The following is a description of a gene set: studied in species Mus musculus Genes negatively differentially expressed in cell type: cDC1 (conventional dendritic cell type 1) upon treatment with cytokine: LIF in mouse lymph nodes in vivo. from publication Cui A, Huang T, Li S, Ma A, Pérez JL, Sander C, Keskin DB, Wu CJ, Fraenkel E, Hacohen N (PMID 38057668) Cytokines mediate cell-cell communication in the immune system and represent important therapeutic targets. A myriad of studies have highlighted their central role in immune function, yet we lack a global view of the cellular responses of each immune cell type to each cytokine. To address this gap, the authors created the Immune Dictionary, a compendium of single-cell transcriptomic profiles of more than 17 immune cell types in response to each of 86 cytokines (>1,400 cytokine-cell type combinations) in mouse lymph nodes in vivo. A cytokine-centric view of the dictionary revealed that most cytokines induce highly cell-type-specific responses. For example, the inflammatory cytokine interleukin-1β induces distinct gene programmes in almost every cell type. A cell-type-centric view of the dictionary identified more than 66 cytokine-driven cellular polarization states across immune cell types, including previously uncharacterized states such as an interleukin-18-induced polyfunctional natural killer cell state. Mouse Gene Set: CUI_CDC1_LIF_RESPONSE_DN, and this is the list of marker genes: Kctd12, Klf2, Lyz2, Nedd4, Fosb, Mpeg1, Ccr2, Parp8